Given this list of marker genes Cartpt, Rapgef4, Il6, Gba1, Cntnap2, Chrnb4, Ffar3, Hcrt, Pawr, Mtnr1b, Tnr, Itga2, here is a description of the gene set: Mouse Gene Set: GOBP_POSITIVE_REGULATION_OF_TRANSMISSION_OF_NERVE_IMPULSE Any process that activates, maintains or increases the frequency, rate or extent of transmission of a nerve impulse, the sequential electrochemical polarization and depolarization that travels across the membrane of a neuron in response to stimulation. studied in species Mus musculus